The following is a description of a gene set: studied in species Mus musculus Any process that results in a change in state or activity of a cell or an organism (in terms of movement, secretion, enzyme production, gene expression, etc.) as a result of a granulocyte macrophage colony-stimulating factor stimulus. Mouse Gene Set: GOBP_RESPONSE_TO_GRANULOCYTE_MACROPHAGE_COLONY_STIMULATING_FACTOR, and this is the list of marker genes: Stat5a, Akt1, Mir21a, Jak2, Csf2, Etv3, Zfp36, Pde1b, Pde2a, Npr2, Zfp36l2, Prlr, Mir155, Cd4